Given this list of marker genes RLIM, PNKP (NCBI Gene Id 11284), TRHR, DRD4, NDUFB3, DGCR8, ANLN, BCOR, PER2, CLRN1, CEP85L, GPR35, MT-CYB, SOX6, MIR17HG, GLI2, GABRB3 (NCBI Gene Id 2562), ALDH4A1, NDUFB9 (NADH:ubiquinone oxidoreductase subunit B9), CLCA4, SLC5A5, KRAS, LHX3, NDUFA6, RAD21, HERC2, KRT18, TLR4, HADH, BBIP1, RYR1, PPARGC1A, DNMT1, FGF8, HPD, MTHFS, ARG1 (NCBI Gene Id 383), CACNA1I, DEAF1, PHOX2B, PGAP1, SNORD116-1, IBA57, UBE2A, NONO, TMEM240, IL12A-AS1, WFS1, LIMK1, CDK19, AMPD2, OCRL, NDUFS2, FLCN (NCBI Gene Id 201163), KMT2A, ZNF365, UBAC2, KCNB1, PTS, DNMT3A, COX5A, GABBR1, FGFR3, SMARCD1, CEP290, GNB1, ZNRF3, CLIP2, SLC26A9, ANKRD17, CEACAM3, TSHB, RPL35A, HACE1, PLPBP, IVD, NAGLU, HMGCL, FXN, DPF2, PPP1R21, HMBS, ATP6V1A, APOL1 (NCBI Gene Id 8542), DRD2, CCBE1, RAB39B, NDUFB10, UROC1, ACTN4, LZTFL1, PODXL (NCBI Gene Id 5420), MT-ND4, COASY, SMC5, PGK1, NEXMIF, SNCAIP, PI4K2A, TSEN15, ARID1A, TDO2, CP, DENND5A, BRAT1, MIF, KAT5, SLC20A2, ACADSB, ABCA7, NUP205, AP3B2, NKAP, PIGA, RPS7, TRANK1, PTEN, KPNA3, ENTPD1, FBXW11, CARS1, DPYS, IL23R, SLC32A1, CDH11, OCA2, GSN, RREB1 (ras responsive element binding protein 1), PTPN22, SMARCA2, WDPCP, KCNN4, CEP78, NTNG2, ODC1, RPS29, NDUFS4, MT-ND6, MED25, NRCAM, CA5A, TAMM41 (TAM41 mitochondrial translocator assembly and maintenance homolog), CLN6, TUBG1, CFAP410, SLC7A6OS, APP, IFT74, CACNB4, RPL5, FRRS1L, GUF1, ITGAM, PCCA, KDM1A, ABCD1, TPO, TTC8, SLC52A1, COX10, PCCB (NCBI Gene Id 5096), TTI2, PROP1, NDUFA2 (NCBI Gene Id 4695), MID2, EPM2A, PSMB1, GAMT, GABRA5, HTRA1, MLXIPL, CASK, TRIM32, EIF4H, ATP2A2, JPH3, MTRR, ERBB4, AR, SNORD118, TAF4, KCNC2, ATXN10, DCTN1, GDAP2, LMAN2L, RARS2, MAPK10, TRIM8, PRKAR1A, SPTBN1 (NCBI Gene Id 91654), ADH1C, TMEM106B, USH1C, LINS1, PTCHD1, ABCC6, NUBPL, DHCR7, FBP1, ACADS, COG8, NODAL (NCBI Gene Id 8114), SPRED1, PUF60, ZBTB20, CIB2, TBP, GNRHR, CPS1, IL1RAPL1, SMC1A, NOTCH3, STX16 (NCBI Gene Id 8675), PTCH1, FCGR3B, CILK1, SCN2A, KISS1, POU1F1, HTRA2, HESX1, PLAG1, BMP6, DNAJC21, PIDD1, CRH, NLGN4X, NDE1, VAPB, TACR3 (NCBI Gene Id 6870), PFN1, THOC2, RPS15A, CIC, SYNJ1, RFX7, SUCLA2, NDUFAF3, ELP2, SPR, GLI3, FDFT1, NBAS, ALK, DNM1, MT-TW, ITPR1, IGF1R, ASAH1, NR4A2, NDUFAF1 (NADH:ubiquinone oxidoreductase complex assembly factor 1), STS, HLA-DRB1, TAF1, SMC3, SETBP1, MAOA (NCBI Gene Id 441491), TPH2, PRPH, ACBD6 (NCBI Gene Id 84320), PPP1R12A, BCAP31, CHD7, NOVA2, NUP93, HEXA, VPS35, PDZD7, EIF2S3, TET3, BBS10, DGCR2, GRIN2A, IRAK1, TELO2 (NCBI Gene Id 9894), NAA60, TRAK1, ALAD, RERE, CAMK2A, P4HA2, CHRNB2, MMAA, GLRA2, LINGO1, MKS1 (MKS transition zone complex subunit 1), HDAC4, SERPINA1, AQP2, BBS12, RPS19, KDM5B, DNAJC13, CHEK2, DNM1L, MT-CO2, NPAP1, GRIA1, PROKR2, SLC6A4, MAPT, ATP13A2, CYP24A1, ENSG00000288330, HDC, NUP85, STUB1, KDM6B, IRF5, ASPA, DYRK1A, PXK, ZIC2, SLC6A3, KIAA0319L, VANGL1, SCO2, XK, ADA2, SOX11, BNC2, NBEA, CACNA1B, AGO1, PLA2G6, DAOA, HTR2A, TCF4, TAF6, IGHG1, DNAJC30, SOD1, POLE, CFTR, SZT2, IFNG, CPT1A, AVP, MST1, FAS, FKBP6, CLTRN, NEK1, FTSJ1, IDUA, NSDHL, PTPA, AHDC1, RNF125, OPHN1, PARS2, MCTP2, APOE, PON2, RPL31, CDH23, HUWE1, SLC25A4, RAC1 (Rac family small GTPase 1), SLF2, UQCRC1, GPR101, DUOXA2, SATB2, ENPP1, SARS1, ASS1, USP9X, METTL27, AIFM1 (NCBI Gene Id 9131), GIGYF2, TNFSF4, GNS, NFIB, SPART, TARDBP, FRMPD4, HS6ST1, SIK1, GTF2I, RPS10 (NCBI Gene Id 6204), SLC6A8, CDKN1C, SHANK3, GAPVD1, ARX, RIC1, ATXN1, C19orf12, SLC9A3, THRB, ASCC3, NKX2-5, TIAM1, LIG4, ECE1, UBAP2L, RPL8, PIK3CA, SMARCA4, SPTAN1, ACTL6B, FTL, VPS13C, GCSH, GABRG2, PLCH1, MT-TH, ALDH7A1, HIRA, WDR45 (WD repeat domain 45), HIVEP2, MED13, DCTN4, KMT2E, COG4, MT-ND5, NHLRC1, SGSH, NEFH, TGFBR2, DNAJC5, RNF168, MT-ND2, MAPK1, SNCA, UBE3C, GTF2IRD2, HLCS, POLG2, TIMMDC1, TP53, MT-TN, TERT (NCBI Gene Id 7015), EHMT1, TOR1A, TNIP1, DISP1, VDR, SYT1, CABP4, KNL1, EBP, BOLA3, DPYD, ALPL, SLC11A1, APOL2, SLC2A3, GP1BB, PYGL, PPP2R5D, ARHGAP24, PTH, NUP160, TK2, MMUT, ARMC5, DGCR6, PDE4D, BCR, PMS1 (PMS1 homolog 1, mismatch repair system component), ATP9A, FA2H, NR1H4, NSD1, NDUFV2, GNAO1, PRRT2, MBD5, SDCCAG8, CHD8, FBP2, YWHAG, CDKN2B, IYD, SRCAP, LNPK, TBC1D2B, NHLRC2, KIF15, JARID2, CACNA1G, UPF3B, AIP, ESS2, SPG21, ADAR, FGD1, DAAM2 (dishevelled associated activator of morphogenesis 2), CYP2R1, USP18, PUS3, SPRY4, SCN1B, ACOX1, VPS37D, PDGFB, LMBRD1, ELN, RPS27, ARSA, SDHAF1, CASR, AP2M1, PHIP, SMPD1, PSEN1, AFF2, SLC13A5, MMADHC, GABRA1, ATXN8OS, UFC1, PRF1, EIF2AK1, SPAST (spastin), KLRC4 (killer cell lectin like receptor C4), PACS2, FOXP2, ASNS (asparagine synthetase (glutamine-hydrolyzing)), FGF12, CSNK2A1, DGUOK, CCR1, SHMT2, IFT172, TLK2, UBE3A, TSR2, ASPM, GRIN1, MED12L (mediator complex subunit 12L), KCNT1, DHTKD1, CTCF, CLCNKA, TBX1, SEPSECS, NDUFS3, IMPA1, LRRK2, SDHD, BAZ1B, NFIX, SLC4A1, CDK10, MAPK8IP3, FUZ, CTSF, CNBP, TAF15, HLA-B, NAA15, NFIA, NAXD, CHRNA7, DMXL2 (Dmx like 2), CHCHD10, SASS6, HLA-DQB1, HECTD4, DNASE1, NPHP1, NEFL, USP48, SLC39A4, PAK3, RNU7-1, CRBN, TRAPPC9, CUX2, SLC4A10, MATR3, TMEM222, SMAD4, HSPG2, FLI1, TUBB3, CTLA4, CCNF, KDM5C, ATP6V0A1, SDHA, WDR62 (NCBI Gene Id 4181), GLS, WWOX, DDC, CISD2, STEEP1, ANAPC1, GCLC, ITPA, POGZ, ANG, COQ5, FOXE1, CEACAM6, GTF2IRD1 (GTF2I repeat domain containing 1), ZNF292, GAS1, PIGQ, RRM2B, DEPDC5, NR3C1, YIF1B, NSD2, CRIPTO, EBF3, NCF1, RPS24, CYP27B1, RNASEH2A, RSRC1, SMO, DDX59, NDUFA11, NDUFAF2, ABCC8, IGF2, HCRT, SETD5, MMAB, FBXO11, SCN1A, PIGL, DRD5, ARID1B, SLC39A14, UCHL1, TRPC6, HADHA, DARS1, ABCD4, ABAT, ADSL, GCH1, BRCA2, RPL18, PEX2, DCDC2, HAL, SNORD115-1, C4B, LIN28B, CELF2, KDM4B, PDE11A, MYCN, SLC6A1, SORL1, NIPA2, FGF14, MTR, LAS1L, PPT1, MED23, FUS, SUGCT, AGO2, DYNC1I2, NDUFB11, ACY1, SPP1, TCF20, PAH, POLG, TNPO2, GRM7, RORB, DPYSL5, SLC25A19, TSPOAP1, DHDDS, WAC, RPS20 (ribosomal protein S20), PHGDH, TMEM147, TREM2, PHF21A, MMACHC, UFD1, ZMIZ1, GALT, SLC6A17, BBS5, UNC13A, PIEZO2, SLITRK1, GNA11, FOCAD, SLC6A14, NAXE, MT-ATP8, GRN, RPS17, MT-TF, CACNA1H, NSUN6, IRF4, KCNJ11, TUBB2B (NCBI Gene Id 347733), CDKL5, MAN1B1, NPHS1 (NPHS1 adhesion molecule, nephrin), KCTD17 (NCBI Gene Id 79734), PAX8, IQSEC1, MED13L, HNRNPR, HCN1, GNB2, PSAP, TWNK, KCNN2, MAP1B, CAMK2B, NKX2-1, LSM11, ADAT3, DPH1, SUPT16H, KMT2B, RMND1 (required for meiotic nuclear division 1 homolog), NPHS2, GLUD1, MT-ND1, COG3, ZFX, FGF17, PIGP, APOL4, SLC38A3 (solute carrier family 38 member 3), SMARCE1, SLC9A7, SEMA3E, FLII, GLRX5, MAGEL2, BBS1, FANCD2, PLP1, GABRA2, ATP5MK, PTRHD1, DAO, PERCC1, SLC1A3, GLT8D1, MAN2B1, PCNT, GM2A, ASL, SUOX, IFNGR1, MANBA, C4A, DALRD3, FGFR1, DDX3X, ALDH5A1, HNF1A, ARV1, CACNA2D1, SLC25A20, SARDH, GABBR2 (gamma-aminobutyric acid type B receptor subunit 2), AARS1, KCNQ3, HBB, PDCD6IP, SCAF4, TNRC6B, VPS16, QDPR, TMEM270, YARS2 (NCBI Gene Id 51067), HGSNAT, WARS2, PON1, SOX4, MYT1L, ATXN3, STAG2, SAMHD1, NDST1, BANK1, PWAR1, SCAPER, NDUFS6, WDR11, TREX1, GNE, PPP2CA, GLDC, SUCLG1, FMO3 (flavin containing dimethylaniline monoxygenase 3), CLTC, PDZD8, RPL27, FCGR2B, HOXA2, NACC1, ZMYM3, AVPR2, RNASEH2C, PDE2A, STAT4, RPS6KA3, CUL4B, SEMA4D, GNRH1, OPTN, PRR12, COQ2, VCP, MCCC1, POLR1A, FMR1, PSEN2, PNP, LMO1, SHH, AP2S1 (adaptor related protein complex 2 subunit sigma 1), POLA1, BCKDK, MADD, GATA4, GNB5, FERRY3, GALC, WBP4, TMEM67, TRMT5, FOXP1, WBP11, MKKS, MT-ATP6, NAGS, KCNH5, ADGRL1, USP8, NIPA1, HJV, GYS2, PBX1, LSS, CDON, HTT, UBA5, HIBCH, SLC2A1, RPL35, SLC46A1, LHCGR, FOXRED1, SRPK3, STIL (STIL centriolar assembly protein), CDKN1A, BUD23, TBK1, HFE, NDP (norrin cystine knot growth factor NDP), USH2A, MAB21L1, SUFU, VPS50, STXBP1, WT1, TRAPPC10, SLC19A3, GRIA4, PINK1, TMCO1, CBS, TRAF7, COL4A3, MSTO1, BRAF, XPR1, HNRNPK, CLCN4, NAA10, SOX5 (NCBI Gene Id 6660), ZMYM2, PROK2, ATP1A1, ALG12, GABRD, TANC2, CHKA, NDUFAF5 (NCBI Gene Id 79133), H4C5, IGF1, MAGI2, RNU4-2, CACNA1C, NF2, ARSG, TTC5, MCCC2, BRD4, ATPAF2, MT-ND3, DNAJC6, JAZF1, SLC16A2, KCNA1, DLG3, CREBBP, RAI1, AQP4, ANKRD11, ADCY5, PRKCG, ABCB7, ST3GAL3, BCKDHB, KISS1R, NLGN3, SCLT1, TRAPPC14, USP7, GPRC5B (NCBI Gene Id 51704), ATXN7, NDUFS7, KIF14, SPG11 (NCBI Gene Id 80208), EDNRA, TLR3, CTSH, CD2AP, NECAP1, PRKACA, NF1, ZFYVE26, PRODH, TGFB1, CNKSR2, SRPX2, RFC2, SH2B1, OTC, IQSEC2, CPOX, ADH5, INF2, SQSTM1, PPP2R2B (NCBI Gene Id 56686), CDKN1B, SLITRK2, SIX3, SYN1, ARID2, DCX, MTHFR, COL7A1, SPG7, SMARCC2, C9orf72, SLC25A15, BRF1, UQCRQ, GATAD2B, SCN3A, HEATR3, ACADVL (acyl-CoA dehydrogenase very long chain), MICU1, DRD3, DLD, GNAS, LHX4, MSH2, SYNGAP1, RNF13, METTL5, TSC2, NUP133, TIMM8A, AGR2, DPAGT1, SDHB, NFU1, TNIK, PLCE1, CHRNA4, RPS26, SYN2, ATP1A3, PANK2, TUBA1A, SH3KBP1, ABCA2, HLA-DQA1, GSTM3, UQCC2, CASP2, SIN3A (SIN3 transcription regulator family member A), PYCR2, MT-TS2, SATB1, SCN8A, CHD3, CHMP2B, SLC9A6, DBT, PSMD12, PIGY, SEC24C, BBS2, MYO7A, SLC25A36, ATM, MOG, TG, CTNNB1, CAPRIN1, CLP1, BCORL1, NUS1, PWRN1, TTC19, TAC3, TBC1D23, CORO1A, PCDH19, GCDH, CHD2, VPS13A, KCNJ2, CLN8, CAMTA1, RAP1GDS1, EXOSC8, HEPHL1, FIG4, PIGH, SGCE, TCN2, COQ8B, YY1, TFE3, ATP10A, MRPL39, ALG14, FLT4, FBXO28, SLC19A2, PPP3CA, GABRB2, NDUFA1, FLG, NGLY1, BSCL2, RPL9, HAMP, BMPR1A, HNF4A, PAX2, MSH6, SLC6A19, CSGALNACT1, NTRK2, AP1G1, MTOR, UBE2L3, AUTS2, DUSP6, BPTF, HDAC8, MRPS16, HEPACAM, MT-TL2, ACAT1, CACNA1A, BTD, DMPK, MT-TT, MFN2, FANCL, MECP2 (methyl-CpG binding protein 2), NDUFV1, KIF11, FOXH1 (NCBI Gene Id 8928), HNRNPH2, PACS1, BCS1L, PGM2L1, FBXL3, TMEM126B, NAA20, UBE4A, GNAQ, ADGRV1, ATP5F1E, EMP2, ABCB11, RUSC2, IL10, PIGS, BAP1, TBX2, TBC1D7, ACADM, PCGF2, HMGA2, TFAM, AP1S2, NSUN2, SLC31A1, CDK8, IKBKG, SPEN, KCNA4, HMOX1, CC2D1A, ECM1, STT3A, STX1A, SLC1A2, AMACR, PPP2R1A, SLC52A2, WHRN, CYFIP2, TNFAIP3 (TNF alpha induced protein 3), ATP8B1, INPP5E, ADNP, MAMLD1, ESPN, SLC25A22 (solute carrier family 25 member 22), COMT, GK, ALDOB, ELP1, MTPAP, PRDX1, EIF2B1, TMEM237, ATP5F1A, SIM1 (NCBI Gene Id 6492), DLL1, MEFV, MPV17, PDHA1, AOPEP, APC2, ATP7B, ARPC4, CDKN2C, AFG3L2, KDM3B, PMS2, TRIO, GRIA3, TSHR, LGI1, CPT2, FZR1, SETD1A, RNASEH2B, BBS9, RPL15, GBA1, AASS, H3-3A, NUP37, PRKN, MT-TQ, RELN, UCP2, CNTNAP2, KMT5B, EFHC1, DYM, FOXG1, UBTF, MOCS2, HSD17B10, SLC7A7, TKT, TGIF1, CUL3, MUTYH, DPP6, HIKESHI, PUS7, OSTM1, NDUFAF4, TAOK1, TBL1X, ZDHHC9, NLGN1, NFS1, GRIK2, ANXA11, HNRNPA1, EEF1A2, CDC42BPB, DNA2, NIPBL, PRKD1 (protein kinase D1), MYO1E, ALKBH8, ERAP1, CEP152, ZMYND11, AKT1, SLC1A4, TYROBP, CLCNKB, CHI3L1, RTN4R, EPCAM, SLC25A1, SHOC2, NR2F1, TLR7, TTI1, ALG9, DPH2, EIF4A2, ZSWIM6, IMPDH2, BCKDHA, KANSL1, ANKFY1, RPL26 (NCBI Gene Id 6154), ARL6, PER3, SCN9A, NDUFS1, SLC26A4, TOMM40, TRIP12, ATXN2, NOP56, CHD5, DDB1, SCARB2, KCNK9, NUP107, HADHB, TBC1D8B, EIF4G1 (eukaryotic translation initiation factor 4 gamma 1), AARS2 (NCBI Gene Id 57505), CLCN3, IFIH1, FKBP5, LYRM7, POU4F1, EP300, TBL2, MT-CO3 (mitochondrially encoded cytochrome c oxidase III), CDH2, SLC25A13, TRMU, B4GALNT1, CRB2, CHAMP1, ATRX, SEMA4A, KCNA2, NEUROD2, CHRNA2, ATP5F1D (NCBI Gene Id 513), ARHGDIA, CLCN2, GATA1, POLD1, JRK, P2RY11, BLK, MMP1, GLA, GLE1, SHROOM4 (NCBI Gene Id 57477), MT-TL1, EXOC8, MKRN3, CHCHD2, RPS28, USH1G, PCDH15, PPM1D, SRRM2, IFT27, YME1L1, CR2, RPL11, ATP1A2, TIMM50, NTRK1 (neurotrophic receptor tyrosine kinase 1), PCBD1 (NCBI Gene Id 5092), MGAT2, HARS1, SNRPN, ETS1, CSF1R (colony stimulating factor 1 receptor), SMARCB1, PDGFRB, BBS7, NTNG1, NBN, BBS4, PDCD1, ANK3, TSC1, IL12A, PON3, TSEN54, ST3GAL5, CYP27A1, ATR, DNAJC12, NDUFAF8, NHLH2, WDR4, NDUFS8 (NADH:ubiquinone oxidoreductase core subunit S8), KAT8, BSND, MED12, NFASC, MEN1, PRNP, LEPR, LGI3, SLC22A5, SETD2, RBBP8, ARVCF, NSMF, TMEM231, ABCB4, TH, VPS53, PRKAR1B (protein kinase cAMP-dependent type I regulatory subunit beta), CRKL, UBQLN2, CDKN2A, PARK7, DUOX2 (NCBI Gene Id 82430), TSFM, CFAP418, ASH1L, CEP19, MLH1, MT-CO1, GRIN2D, GFAP, CNP, PTPRO, JMJD1C, here is a description of the gene set: Abnormal affect studied in species Homo sapiens Human Gene Set: HP_ABNORMAL_AFFECT An anomaly in intensity, frequency, or duration of the verbal or behavioral expression of emotions, feelings, or thoughts.